Given this list of marker genes Dnlz, Tmem35a, Stub1, Lonp1, Hsp90aa1, Hspa4, Mkks, Psmg2, Bbs10, Psmg1, Bbs12, Hsp90ab1, Hopx, Cct2, Psmg3, Pfdn6 (NCBI Gene Id 14976), Clu, Ptges3-ps, Ptges3l, Ndufaf1, Ptges3, here is a description of the gene set: Mouse Gene Set: GOBP_CHAPERONE_MEDIATED_PROTEIN_COMPLEX_ASSEMBLY studied in species Mus musculus The aggregation, arrangement and bonding together of a set of components to form a protein complex, mediated by chaperone molecules that do not form part of the finished complex.